The following is a description of a gene set: species: Homo sapiens Genes predicted to be targets of miRBase v22 microRNA hsa-miR-24-1-5p, hsa-miR-24-2-5p in miRDB v6.0 with MirTarget v4 prediction scores > 80 (high confidence targets). from publication Chen Y, Wang X (PMID 31504780) Human Gene Set: MIR24_1_5P_MIR24_2_5P, and this is the list of marker genes: MYBL1, SRPK2, CALD1, TNFAIP8, CABYR, RYBP, HLCS, SRSF11, LAMTOR3, GLG1, TM9SF3, TREM1, AFAP1L1 (NCBI Gene Id 134265), ZNF367, KCNJ6, FMR1, GZF1, EDIL3, SLC6A5, NXPH1 (NCBI Gene Id 30010), DNAJC10, C2orf49, CERS6, TRIM14 (NCBI Gene Id 9830), MFSD1, EGLN1, TSSK2, ARHGAP20, ZNF770 (zinc finger protein 770), ACADSB, SLC5A3, ASPH, MDM1, ZBTB43, RNF170, BIRC3, ZNF670, C21orf91, HNRNPU, ACTR2, PCDH9, ZNF470, XIAP, SPTY2D1, IGIP